The following is a description of a gene set: studied in species Homo sapiens Reactome Pathway: Prostanoid ligand receptors Fatty acid cyclo-oxygenase (COX) converts arachidonic acid to prostaglandin H2 (PGH2) from which the prostanoids PGD2, PGE2, PGF2alpha, PGI2 (prostacyclin) and thromboxane A2 (TXA2) are derived. Based on the agonist potencies, five prostanoid receptors are recognized and correspondingly named DP, EP, FP, IP and TP receptors (Coleman RA et al, 1994). Additionally, EP receptors contains four subtypes, termed EP1, EP2, EP3 and EP4; the DP receptor also has two subtypes, DP1 and DP2 (CRTH2). part of: Eicosanoid ligand-binding receptors, and this is the list of marker genes: PTGDR2, PTGER4, PTGER2, PTGIR, PTGDR, TBXA2R, PTGER3, PTGFR, PTGER1